Given this list of marker genes TGFB1, KLF4, PKN2 (protein kinase N2), PDPK1, XBP1, KLF2 (KLF transcription factor 2), SMAD6, MAPK7, CAPN2, NFE2L2, PRKACA, AKT1, PRKACB, PRKACG, MAP2K5, ABCA1, MTOR, GNAS, MIR126, ASS1, SMAD7 (SMAD family member 7), SREBF2, here is a description of the gene set: Any process that results in a change in state or activity of a cell or an organism (in terms of movement, secretion, enzyme production, gene expression, etc.) as a result of a laminar fluid shear stress stimulus. Laminar fluid flow is the force acting on an object in a system where the fluid is moving across a solid surface in parallel layers. As an example, laminar shear stress can be seen where blood flows against the luminal side of blood vessel walls. Human Gene Set: GOBP_RESPONSE_TO_LAMINAR_FLUID_SHEAR_STRESS species: Homo sapiens